Given this list of marker genes WDR19, DHH, PSMB3, TTC21B, OS9, ADCY1, PRKACA, PSMD2, GAS8, GAS1 (NCBI Gene Id 2619), SMURF2, SPOPL, PSMA5, TUBA1C, IFT57, PSMD6, GLI3, UBA52, IFT52, TUBA3C, PSMD13, IFT140, ITCH, ARRB1, PSMD8, PSMB1, FUZ, TUBA1B, ADCY5, CSNK1A1, INTU, DISP2, GPC5, PRKAR1A, TUBB3, SPOP, EVC2, PSMD1, PSMA4, DERL2, IFT172, IFT88, WDR35, ADCY4, TUBB2A, PSMC4, DZIP1, PSMA1, PSMD14, PSMC5, CUL3, SHH, TUBB1, ARRB2 (NCBI Gene Id 409), GLI1, TUBA3D, PRKACG, HHIP, PSMD7, ADCY6, PSMD3, PSMC3, ERLEC1, TUBB4B, GLI2, PSMD11, CDON, PSMD12, SKP1, CDC73, PTCH1, PRKAR2A, EFCAB7, GRK2, SEL1L, ADCY2, PSMB2, OFD1, PSMA3, TUBA1A, SMURF1, VCP, EVC, SYVN1, GSK3B, SMO, ADCY8, P4HB, PRKAR1B, PSMB6, MKS1, PRKAR2B, IQCE, HHAT, ADAM17, IFT122, TUBA4A, TUBB4A, TUBB6, RPS27A, TUBB2B, PTCH2, IHH, PSMB5, TULP3 (TUB like protein 3), PSMA7, NOTUM, CUL1, PSMC1, PSMB4, RBX1, PSMC6, SUFU, RPGRIP1L, GPR161, SCUBE2, ADRM1, PSMA6, DYNC2H1, BTRC, GNAS, ADCY7, UBC, PSMB7, UBB, KIF7, KIF3A, ADCY10, PSMC2, NUMB, BOC, ULK3, SEM1, PSMA2, PRKACB, ADCY9, ADCY3 (adenylate cyclase 3), here is a description of the gene set: Signaling by Hedgehog studied in species Homo sapiens Human Gene Set: REACTOME_SIGNALING_BY_HEDGEHOG